The following is a description of a gene set: Genes up-regulated in primary fibroblast cell culture after infection with HCMV (AD169 strain) at 14 h time point that were not up-regulated at the previous time point, 12 h. Human Gene Set: BROWNE_HCMV_INFECTION_14HR_UP from publication Browne EP, Wing B, Coleman D, Shenk T (PMID 11711622) The effect of human cytomegalovirus (HCMV) infection on cellular mRNA accumulation was analyzed by gene chip technology. During a 48-h time course after infection of human diploid fibroblasts, 1,425 cellular mRNAs were found to be up-regulated or down-regulated by threefold or greater in at least two consecutive time points. Several classes of genes were prominently affected, including interferon response genes, cell cycle regulators, apoptosis regulators, inflammatory pathway genes, and immune regulators. The number of mRNAs that were up-regulated or down-regulated were roughly equal over the complete time course. However, for the first 8 h after infection, the number of up-regulated mRNAs was significantly less than the number of down-regulated mRNAs. By analyzing the mRNA expression profile of cells infected in the presence of cycloheximide, it was found that a minimum of 25 mRNAs were modulated by HCMV in the absence of protein synthesis. These included mRNAs encoded by a small number of interferon-responsive genes, as well as beta interferon itself. Cellular mRNA levels in cytomegalovirus-infected cells were compared to the levels in cells infected with UV-inactivated virus. The inactivated virus caused the up-regulation of a much greater number of mRNAs, many of which encoded proteins with antiviral roles, such as interferon-responsive genes and proinflammatory cytokines. These data argue that one or more newly synthesized viral gene products block the induction of antiviral pathways that are triggered by HCMV binding and entry. species: Homo sapiens, and this is the list of marker genes: TAF6L, PPP2R2A, MARCKSL1, ATP6V0B, RSRP1, ATF2, PPM1D, ATP6V1C1 (NCBI Gene Id 528), ZNF202, HLA-F, CEBPG, PRP4K, GRPEL1, BCL7B, FEN1 (flap structure-specific endonuclease 1), CLINT1, HYAL2, FMO1, ZNF263, RCHY1, DDX3Y, LUC7L3, PRPF3, ANP32E, ABCC5, FAM161A, CBARP, UPF2 (NCBI Gene Id 26019), TAC1, FZD5, KNG1, TIAM1, MED1, CCNA1, RBM14, UBE2S, FICD, M6PR, JMJD6, SYNE2, H3C4, GCLM (glutamate-cysteine ligase modifier subunit), TRIM23, SRRT, UBN1, AQP3, CCNF, THUMPD1, TARS1, POLR2H, BRMS1, USPL1, MORC3, TSFM, NEU1, MAX, TFEC, H2AC8, ERVW-1, APOE, CCNE1, CGRRF1, PNO1, HOXB2, CDR2, AMD1, ZNF20, GAPVD1, NFATC3, HES1, FOXK2, EIF4EBP3, DDX39A, KLHL18, NXF1, BMP6, CCDC93, BAZ1A, CDS1, EIF4A3 (NCBI Gene Id 9775), ZNF44, ALAS1, ING1, POLE3, CCNE2, SLC39A14, VCP, PNN, DDX3X (DEAD-box helicase 3 X-linked), FOS, SPAG1, RPIA, EPHA4, ETV5, CALCRL, ZNF230, TAF1A, SIAH2, TENT4A, MAPK8IP2, GP5, DBF4, HINFP (histone H4 transcription factor), IP6K1, HIPK1, TIMM44, ZNF200, ADNP2, PDIA4, AGTR1, RGS19, ZNF410, HERPUD1, GLA, LINC02802, SNHG29, SAFB2, CPA3, SMG7, KLHDC10, ZNF56P, ZBED4, EYA4, SULT1A2, MNDA, POT1, SLC7A5, PPFIA1, CEP43, ZNF143, USP1, PRUNE1, TSPYL2, UPF1, UBE2M, ZNF204P, SYNJ1, SMURF1, HMOX1, TOP1, GCLC, TAF5, RCC1, LEF1, DLX2, NTS, CERS6, DCTN5, GPM6A, ISG20L2, ZNF266, GAGE1, PTGDS, CDC6, NDEL1 (NCBI Gene Id 81565), CDK2, TSC22D3, H2BC11